Given this list of marker genes Necab2, Nlgn3, Unc13a, Prnp, Frrs1l, Shank3, Cx3cl1, Ephb2, Fyn, here is a description of the gene set: Any process that modulates the frequency, rate or extent of glutamate receptor signaling pathway. species: Mus musculus Mouse Gene Set: GOBP_REGULATION_OF_GLUTAMATE_RECEPTOR_SIGNALING_PATHWAY